Given this list of marker genes EVL, NME3, FRG1, PAX5, TNIP1, HES6, GTF3C1, HELB, CAT, GNAI2, RASA3, KLF7, HDAC7, LDAH, SMIM11, DSTN, ATM, ERAL1, ANAPC11, PGM2, RSPH3, MYH9, TAX1BP1, CTSH, MRPL43, LYRM2, ITPR2, GMNN, SEMA5A, ABHD8, SGPP1, COX8A, OAZ2 (NCBI Gene Id 4947), SLC25A28, GLE1, IFT25 (intraflagellar transport 25), CD79B, TMED7, FAM3A, MORC4, MED10, TXNIP, NFYC, SEMA4B, FEZ2, MDFIC, GNA15, CMPK2, FH, TRAF5, ASXL1, SPRYD7, GGA2, TRDMT1, NISCH, FNTA, GDPD3, RIOK3, NEK1, PDK1, MLX, TEX9, SEPTIN9, ZDHHC14, COA6, COMT, DOCK2, XPC, RFC5, S1PR4, H3-5, HSD17B11, SLC25A4, MTERF2, DPAGT1, CCDC90B, ADPRH, BRCA1, NIPSNAP2, STX4, PON2, GOLM1, NDUFB5, SH3BP1, HLA-DOA, LPL, ZFP90, SLC44A1, UNC119, EXOSC4, TGDS, AIMP1, ANP32A, PRAF2, CPSF3, MX1, ZNF436, SIRT3, AKR1A1, CDCA7L, ADAM17, MXI1, IMPA2, IMMP1L, PDE6D, PRMT1, LTB, CHAD, RALGPS2, YJU2, RPN2, PCCB, CDKN2C, CBFA2T3, PRPSAP1, CHD8, COX18, DPP4, ZBTB25, SOX11, RPAP3, BTG2, INPP5K, HHEX, CS, CBX4, ATXN7L3B (NCBI Gene Id 552889), SLC37A4, CCNG2, SLC38A10, ITSN1, HADH, TAPBP, NPC1, GPSM3, CAST, PARN (NCBI Gene Id 5073), UBA7, KDM3B, DDT, UNC119B, RAB12, GNA11, MX2, PDGFRB, MRPL40, STARD3, SOX13, CCNF, TRAPPC1, CAMLG, CXorf38, AKTIP, OCM2 (oncomodulin 2), CDK2AP2 (cyclin dependent kinase 2 associated protein 2), SULT2B1, RFC1, ARL14EP, DDX19B, COG5, GCNT1, LIPE, ADD1, KLF13, TOR2A, CD22, PTCD2, MFHAS1, GBF1, FKBP7, HDDC2, SEMA4D, TMEM229B, INTS7, C6orf89, PAPSS1, SLC48A1, CRYBG1, RHOQ, COX7A2L, HTATIP2, CPNE1, APOBEC1, NDUFS3, TAF1B, FBXO21, TXNDC5, AHNAK, PSMB9, OSBPL5, RNPEP, GLOD4 (glyoxalase domain containing 4), HCFC1R1, SUMF1, SNIP1, ESYT1, RNF167, NONO, GM2A, KCND2, here is a description of the gene set: Genes down-regulated in CD4 SMARTA effector T cells during acute infection of LCMV: Th1 versus Ly6c low CXCR5-. studied in species Homo sapiens from publication Hale JS, Youngblood B, Latner DR, Mohammed AU, Ye L, Akondy RS, Wu T, Iyer SS, Ahmed R (PMID 23583644) Human Gene Set: GSE43863_TH1_VS_LY6C_LOW_CXCR5NEG_EFFECTOR_CD4_TCELL_DN CD4 T follicular helper (Tfh) cells provide the required signals to B cells for germinal center reactions that are necessary for longlived antibody responses. However, it remains unclear whether there are CD4+ memory T cells committed to the Tfh lineage after antigen clearance. Using adoptive transfer of antigen-specific memory CD4+ subpopulations (based on CXCR5 and Ly6c expression)in the LCMV infection model, we found that there are distinct memory CD4+ T cell populations with commitment to the Tfh and Th1 lineages. Our conclusions are based on gene expression profiles, epigenetic studies and phenotypic and functional analysis. The gene expression profiles of virus-specific CD4 T cell subets at effector and memory stages is presented here.